Given this list of marker genes Sox4, Eya1, Fkbp10, Tgfbr2, Col3a1, Kat6a, Fgf8 (NCBI Gene Id 14179), Mir145a, Hey1, Dll4, Srf, Tfap2b, Bmpr1a, Tgfb2, Six1 (sine oculis-related homeobox 1), Chd7, Hes1, Nprl3, Naglu, Jag1, Notch1, Lrp1, Tbx1, Eng, Acvrl1, Hey2, Mylk, Mir143, Adamts9, Notch4, Rbpj, Prox1, Sec24b, Efnb2, Ephb4, Efemp2, Tbx2, Pdgfrb, Foxh1, here is a description of the gene set: Mouse Gene Set: GOBP_AORTA_MORPHOGENESIS species: Mus musculus The process in which the anatomical structures of an aorta are generated and organized. An aorta is an artery that carries blood from the heart to other parts of the body.